Given this list of marker genes IRS2, GDF15, FABP3, FMO1, MLYCD, ACACB, SIRT4, PPARA, FMO2 (NCBI Gene Id 2327), CPT1A (carnitine palmitoyltransferase 1A), ABCD1, PPARGC1A, MTLN, KLHL25, AKT2, MFSD2A, ABCB11, IRS1, PDK4, PLIN5, ACADL, ACADVL, PRKAG2, ETFBKMT, ABCD2, PPARD, TYSND1, APPL2, AKT1, TWIST1, LONP2, SOX9, DGAT2 (diacylglycerol O-acyltransferase 2), FMO4, here is a description of the gene set: Human Gene Set: GOBP_REGULATION_OF_FATTY_ACID_OXIDATION species: Homo sapiens Any process that modulates the frequency, rate or extent of fatty acid oxidation.